Given this list of marker genes GNAQ, DAG1, MAB21L1, LRPAP1, LTBP2, FBXO11, POMGNT1, TWIST1, ALKBH8, PIGV, CHSY1 (NCBI Gene Id 22856), ATOH7 (NCBI Gene Id 54719), FKTN, B3GAT3, GLIS3, FGFR2 (fibroblast growth factor receptor 2), PIK3R2, CYP1B1, ATR, NCAPG2, ARX, SCO2, SH3PXD2B, OCRL, TEK, POMT2 (NCBI Gene Id 29954), CPSF1, POMK (protein O-mannose kinase), FKRP, KCNJ1, COL2A1, PXDN, ADAMTSL1, FBN1 (fibrillin 1), NDP, KCNJ6, RNU4-2, FZD4, LARGE1, POMT1, CHST3, MYOC, FUT8, SIX6, SBF2, WDR26, AKT1, CASK, here is a description of the gene set: Human Gene Set: HP_ABNORMALLY_LARGE_GLOBE Abnormally large globe species: Homo sapiens Diffusely large eye (with megalocornea) without glaucoma.